Given this list of marker genes CNDP2, CPQ, CNDP1, DPEP1, MEP1A, ACE, DPEP2, ADAM10, ADAM17, here is a description of the gene set: Human Gene Set: GOMF_METALLODIPEPTIDASE_ACTIVITY Catalysis of the hydrolysis of a dipeptide by a mechanism in which water acts as a nucleophile, one or two metal ions hold the water molecule in place, and charged amino acid side chains are ligands for the metal ions. studied in species Homo sapiens